Given this list of marker genes SHC2 (NCBI Gene Id 400665), SLC29A1, HAUS5, SIN3B (NCBI Gene Id 23309), WDR33, DNAJB2, ZNF358, ZFP37, PKP4 (plakophilin 4), ARID4A, RIPK4, NR2F6, GNA11, EPOR, YIPF2 (NCBI Gene Id 78992), LCMT1, RALGAPA1, GGA2, ARID3A, ZNF562, ZSCAN18, ARMCX5, RANBP3, PDK2, KLHL26, SMARCA4, ASIC3, ADGRL1, CERS4, HOOK2, OTUD3, CD2BP2, FBRS, DNAJB1, FZR1, SEZ6L2, ZNF444, CA10, VSIG10, MKNK2, DHRS2, DLX4, ARHGEF18, SYT17, KDM4B, RUFY3, PLPPR2 (phospholipid phosphatase related 2), L3MBTL1, CDIP1, TSN, ZNF34, ZNF177 (NCBI Gene Id 7730), DCAF15, RTN2, XAB2, EFS, SLC25A23, CHERP, PGAP1, NPIPB3, AP1M2 (NCBI Gene Id 10053), CDK16, ZNF518A, ANKS1A, SMIM7, ZNF443, ADGRL3, F11R, TLE2, here is a description of the gene set: Human Gene Set: SHEDDEN_LUNG_CANCER_GOOD_SURVIVAL_A5 from publication Director's Challenge Consortium for the Molecular Classification of Lung Adenocarcinoma, Shedden K, Taylor JM, Enkemann SA, Tsao MS, Yeatman TJ, Gerald WL, Eschrich S, Jurisica I, Giordano TJ, Misek DE, Chang AC, Zhu CQ, Strumpf D, Hanash S, Shepherd FA, Ding K, Seymour L, Naoki K, Pennell N, Weir B, Verhaak R, Ladd-Acosta C, Golub T, Gruidl M, Sharma A, Szoke J, Zakowski M, Rusch V, Kris M, Viale A, Motoi N, Travis W, Conley B, Seshan VE, Meyerson M, Kuick R, Dobbin KK, Lively T, Jacobson JW, Beer DG (PMID 18641660) Although prognostic gene expression signatures for survival in early-stage lung cancer have been proposed, for clinical application, it is critical to establish their performance across different subject populations and in different laboratories. Here we report a large, training-testing, multi-site, blinded validation study to characterize the performance of several prognostic models based on gene expression for 442 lung adenocarcinomas. The hypotheses proposed examined whether microarray measurements of gene expression either alone or combined with basic clinical covariates (stage, age, sex) could be used to predict overall survival in lung cancer subjects. Several models examined produced risk scores that substantially correlated with actual subject outcome. Most methods performed better with clinical data, supporting the combined use of clinical and molecular information when building prognostic models for early-stage lung cancer. This study also provides the largest available set of microarray data with extensive pathological and clinical annotation for lung adenocarcinomas. Cluster 5 of method A: up-regulation of these genes in patients with non-small cell lung cancer (NSCLC) predicts good survival outcome. species: Homo sapiens